The following is a description of a gene set: studied in species Homo sapiens Any process that stops or reduces the rate or extent of binding, the selective interaction of a molecule with one or more specific sites on another molecule. Human Gene Set: GOBP_NEGATIVE_REGULATION_OF_BINDING, and this is the list of marker genes: PEX19, STYX, PSEN1, PEX14, EFHB, CARD16, IL10, IFIT1, SMO, CFHR1, CSNK1E, TLE5, PSME3IP1, ILRUN, ITGB1BP1, RACK1, TFAP4, HEY2, SUMO4, BTAF1, ADIPOQ, E2F1, DACT1, WAPL, CAMK1, MIR148A, TNKS, PLN, SUMO3, CFHR5, GZMA, RSF1, LEF1, CARD18, DNAJB2, NES, SLPI (secretory leukocyte peptidase inhibitor), GATA1, SUMO1, ZNF593, CFHR2, DDX11, GNL3L (NCBI Gene Id 54552), MAPK8, PIN1, SYMPK, GTF2F1, XIRP1, MDFI, AURKA (aurora kinase A), CPNE1, HMGA2, TMC8, ADAM15, IFIT2, USP33, RALB, MIR27B, ROCK1, PTPRF, ITGA4, CTNNBIP1, BAX, GOLGA2, LRPAP1, SOX11, IFI16, NFIB, MITD1, GEMIN2, JUN (Jun proto-oncogene, AP-1 transcription factor subunit)